The following is a description of a gene set: Genes containing one or more binding sites for (CSHL1) in their promoter regions (TSS -1000,+100 bp) as identified by GTRD version 20.06 ChIP-seq harmonization. Human Gene Set: CSHL1_TARGET_GENES studied in species Homo sapiens from publication Yevshin I, Sharipov R, Kolmykov S, Kondrakhin Y, Kolpakov F (PMID 30445619), and this is the list of marker genes: ENSG00000214650, APEX1, CCN2, SLC1A4, FKTN-AS1, POLG, BCL10-AS1, WDR11, CFAP97, PTK2, PANK1, TSPAN1, GGPS1, FKTN (NCBI Gene Id 2218), LCLAT1, INTU, TSR2, PPIH, LINC00511, HES1, BCL10, STRN4, RPL14P6, POLA1, PSME2P3, ZNF155, RPS26P29, CDK6-AS1 (CDK6 antisense RNA 1, NCBI Gene Id 101927497), ZNF256, TCF7, PAXBP1, SLC39A13, STAG3L4, FAM98B, DNASE1L3, SP110, H2BC26, POLG-DT, DCPS, RPS27A, NOP53 (NOP53 ribosome biogenesis factor), TMEM109, SLC9A2, HERC3, NCK2 (NCBI Gene Id 8440), TTC28-AS1, LINC01615, IGF2BP2-AS1, SPHK1, SNORD42B, MYH9, NACA, DHX33, DAW1, PLEKHG2, SPRY4-AS1, ARID4B, ADNP, ZNF274, FCF1, PRKAG2, MAGT1, ZGPAT, UQCRC2, CCDC107, PMS2P4, SKIC3, DCC, DLG2-AS2 (NCBI Gene Id 124900639), PANK1-AS1, PARGP1, MIR5188, SPRY4, ADHFE1, EPAS1, NAA40, ENTPD6, IL15 (interleukin 15), LINC02028, GRHL2, CEACAM19, ZNF41, GTF2H4, MTRF1L, NGLY1, FAP, SEC31A, NUDCD1, HLTF-AS1, IER3-AS1, RECQL5, RNU2-2P, TIAM1, TIAM1-AS1, OXSM, ENSG00000267882, KRT17, PRKAG2-AS1, HOOK2, TIMM23, WDR74, SH3TC1, TNRC18, LINC02579, ENY2, DDX39B-AS1, CRIPTOP2, SFTA1P, LINC01607, TAF3, GNAI1, NECTIN4, ALDH3B2, ZNF567, RND3, POLR1F, LINC01354, PYURF, ANKRD18B, MFAP2, SPTLC2, ISG15, ERI1 (exoribonuclease 1), EIF3F, AEBP2, METTL3, TIGD2, SPRR5, OSGEP, TRIM5, ELMOD1, TMX3, DERA, BLOC1S4, ZC3H15, RNF168, ARAP2, RPPH1, HES4, PARP2, ENSG00000233017, ISYNA1, AIMP2, IMMP1L, KDM4A-AS1, FAM182B, MIR4425, RNY4, ANO2, LINC01186, PLAU, TNPO2, CCDST, TASOR2, MBP, DDX39B, DCTN1, SNX25, DBR1, C14orf28 (chromosome 14 open reading frame 28), FADS1, ATP6V1A, ARSK, YJU2, OPA3, SHANK2, DHX33-DT, CYP3A5, WEE2-AS1, ZFAND5, GNAI2, PMS2, OLMALINC, BORCS7 (BLOC-1 related complex subunit 7), COG7, EGFR, NCAPD2, NAPG, GSTA4, FLOT1, URGCP, VARS2, OXR1, CDK6, VPS53, LINC01560, NCS1, SF3B2, IFT88, ENSG00000188897 (novel lipoprotein amino terminal region containing protein), EPCIP-AS1 (NCBI Gene Id 54067), SAP30BP, POM121 (NCBI Gene Id 9883), RAP2B, ANO8, RARA, ARHGEF2, PROSER1, DARS1, LINC02098, H2AC25, AREL1 (NCBI Gene Id 9870), CDK8, KRT14, HEY1, CCDC102B, SSBP1, ADGRL2, SUSD1, ELP4, NHLRC3, THAP9-AS1, PPP1R15A, RBPJ, PLEKHB2, SLC50A1, MGRN1, DOCK9, ENSG00000257346 (novel transcript, antisense to DHH), CLHC1, RPL23A, LINC01415, PCF11, SNORD101 (small nucleolar RNA, C/D box 101), GTF3C3, PRR15-DT, PRR15, BMP1, UBQLN1, BORCS7-ASMT, HRH1 (histamine receptor H1), NDUFA12, HAS3, RASIP1, HM13, DLL4, TNKS1BP1, FOXP4, RPS12, SMURF2P1, ERVK3-1, ZNF567-DT, ANAPC7, ZNF19, ALG11, ATP7B, ARFRP1, GRHL2-DT (GRHL2 divergent transcript), GTPBP3, TIPARP, UBC (NCBI Gene Id 7316), RBBP8NL